The following is a description of a gene set: Mouse Gene Set: GOBP_ENDOCARDIUM_MORPHOGENESIS The process in which the anatomical structure of the endocardium is generated and organized. The endocardium is an anatomical structure comprised of an endothelium and an extracellular matrix that forms the innermost layer of tissue of the heart, and lines the heart chambers. studied in species Mus musculus, and this is the list of marker genes: Sox17, Rbpj, Sox18, Prox1, Notch1 (notch 1), Angpt1, Ovol2